The following is a description of a gene set: DAG and IP3 signaling species: Homo sapiens Human Gene Set: REACTOME_DAG_AND_IP3_SIGNALING, and this is the list of marker genes: PRKAR1B, CAMK4, PRKCG, PRKAR2B, CAMKK1, ADCY1, PRKACG, GRK2, PRKACB, PRKCD, PRKCA, ADCY7, ADCY3, CAMK2D, ITPR3, AHCYL1, ADCY8, PRKCE, ADCY4, CAMK2A, PRKAR2A, PDE1A, CAMK2B, CREB1, PRKAR1A, ITPR1 (NCBI Gene Id 619543), ADCY5, ADCY6, CALM1, PLCG1, ITPR2 (NCBI Gene Id 3709), CAMK2G (calcium/calmodulin dependent protein kinase II gamma), NBEA, PRKX, PRKACA, CAMKK2, PDE1B, KPNA2, PDE1C, ADCY9, ADCY2